Given this list of marker genes TAB1, TAB2, UBC, RPS27A, MAP3K7, UBA52, TIFA, ALPK1, TRAF6, TAB3, UBB, here is a description of the gene set: species: Homo sapiens Alpha-protein kinase 1 signaling pathway Human Gene Set: REACTOME_ALPHA_PROTEIN_KINASE_1_SIGNALING_PATHWAY